The following is a description of a gene set: studied in species Homo sapiens Human Gene Set: chr6p22, and this is the list of marker genes: RNF39, OR2B6, H2AC10P, CDKAL1, H2AC1, OR2H5P, H2AC3P, H2AC5P, BTN1A1P1, BTN3A2, KDM1B (lysine demethylase 1B), OR2E1P, RPL13P, LINC02543, ACOT13, ZSCAN31, GPX6, ARPC3P5, GMNN, RN7SKP240, ENSG00000285761, OR2W1-AS1, SNORD32B, HLA-F-AS1, TRIM26, OR2W6P, OR2B2, POM121L2, NOP56P1, ZNF184, KRT18P38, JARID2-AS1, HLA-L, H4C3, UBQLN1P1, SOX4, RPL10P2, H2BC7 (NCBI Gene Id 8343), CMAHP, TMPOP1, RNU6-190P, H2AC17, HMGN4, H2BC2P, RPL5P20, H2BC3, H1-12P, H4C7, IFITM4P, PAIP1P1, H1-1 (H1.1 linker histone, cluster member), E2F3, E2F3-IT1, OR2B3, H2BC1, H2BC6, H2AC14, KIAA0319, H2AC16, IMPDH1P9, BOLA2P3, H4C8, RSL24D1P1 (ribosomal L24 domain containing 1 pseudogene 1), ENSG00000284607, H3C8, IQCB2P, HCG4, KIF13A, SUMO2P13, HCG11, OR2H1, SCGN, ENSG00000288887, ASS1P1, KRT18P1, SMIM15P2, HNRNPA3P17, HCG14, LNC-LBCS, H2BC12, MAS1L, ZSCAN26, RNU6-263P, HNRNPA1P1, BTN2A1, H2BC9, HCG9, NUP153, TRIM31-AS1, KRT8P43, ENSG00000287626, MCCD1P1, OR14J1, H1-2, NKAPL, RNA5SP205, LINC02829, H3C7, VN1R11P, SAR1AP1, HNRNPA1P58, H3C10, HLA-K, OR2N1P, OR2J1, GPLD1, HLA-F, SCAND3, OR12D3, KAAG1, RNU6-391P, OR2I1P, ZNF204P, C6orf62, HLA-J, DDX6P1, CANT1P1, PGBD1, MYLIP, RNU6-987P, CARMIL1, OR11A1, COX8CP1, RNU6-471P, DDX18P3, LINC01015, FAM8A1, OR2W1, MICC, OR12D2, ZDHHC20P1, UQCRFS1P3, RNU6-645P (RNA, U6 small nuclear 645, pseudogene), MCCD1P2, POLR1H, ENSG00000310015, H2AC15, DDX39BP2, MDH1P2, LOC124906556, OR5V1, LINC00581, RPS17P1, H2BC5, HLA-P, H4C6, LARRPM (NCBI Gene Id 100270746), H3C4, MICE, BTN3A1 (NCBI Gene Id 11119), ARMH2, RNA5SP204, LINC03003, ZSCAN23, HLA-W, RNU6-150P, H3C2, RPL23AP1, LARP1P1, TRIM27, ABT1, TRIM39-RPP21, MAS1LP1, H2BC6-AS1, HCG19P, H4C12, H1-3, ISG20L2P1, ENSG00000199851, OR2B8P, TMEM183AP1 (TMEM183A pseudogene 1), RNU6-502P, OR2W4P, H3C12, OR2W2P, H1-5, ENSG00000251830, SUCLA2P1, HLA-G, OR2U2P, OR2B7P, TRIM26BP, ENSG00000287359, HDGFL1, HLA-A, ENSG00000275846, PPIAP29, ZKSCAN4, UBD, RN7SL471P, ZNF90P2, OR1F12P, TOB2P1, H3P26, H2BC17 (H2B clustered histone 17), SLC17A3, OR2H4P, NBAT1, LINC00240, OR2J3, VN1R10P, LINC01556, RNU7-26P, H2AC6, H3C5P, STMND1, ATXN1-AS1, GPX5, RNU6-522P, CD83P1, H2AC2P, RNU2-62P, RANP1, OR2P1P, BTN2A2, H2BC16P, UBDP1, LINC02828 (NCBI Gene Id 105374978), CDCA7P1, VN1R12P, H2BC11, OR2B4P, RN7SL334P, POLR1HASP, MRPL42P2, MTCO2P33, POM121L6P, H2BC13, ZNF311, TRIM10, ZBED9-AS1, PRSS16, RPL29P17, CAP2, OR2J2, RNF144B, H2BP5, SUMO2P1, TRIM40, ZSCAN12P1, DCDC2, H2BC14, ZNF603P, MICD, H2AC12, MIR548A1HG, ENSG00000299570, TRIM15, MIR4639, ENSG00000305104, RPL6P18, HCP5B, H2AC11, H4C9, MRS2, RPL21P68, ZSCAN12, ZKSCAN8P2, H4C11, HCG18, RNU6-141P, RPL7P26, ZSCAN16, SLC17A4, H2AC9P, TRIM39, COX11P1 (NCBI Gene Id 140468), ZNF322, RNU6-930P, HCG4B, VN1R13P (NCBI Gene Id 387322), TPMT, H3C11, MOG, HLA-T, TRIM31, OR2U1P, OR2H2, HLA-V, KATNBL1P5, H4C2, ZSCAN9, ENSG00000233358, ZFP57, RPP21, H2AC4, HLA-N, ENSG00000288708, NHLRC1, MIR3143, H3C1, LINC03005, LINC01012, RIPOR2, HLA-E, BTN3A3, H2AC13, ESDP1, PRELID1P2, RPL8P1, ZNF165, H2BC10, MIR548A1, H2BC4, SLC17A2, H3C3, H4C4, TRIM38, OR2G1P, HCG9P5, GPR53P (NCBI Gene Id 9292), GPR89P, H1-4, RNU6-1114P, ENSG00000287050, H2AC8, H3C6, HCG15, SLC17A1, ZKSCAN8, DDX39BP1, RNU6-1060P, ZSCAN16-AS1, RPLP2P1, H2BC8, ZNF602P (NCBI Gene Id 493820), MICG, OR2J4P, LINC02980, CASC15, PRL, RPL21P61 (ribosomal protein L21 pseudogene 61), RPL36AP25, PPP1R11, RBM24, OR12D1, H2AC7, MCFD2P1, H3C9P, JARID2-DT, HCG4P8, RPL7AP7, ETF1P1, JARID2, LINC00533, LINC01623, MBOAT1, ATXN1, NUP153-AS1, GMPR, NGRNP4, RNU6-801P, RNU2-45P, OR2AD1P, H2BC15, AP3S1P1, HLA-H, RN7SL128P, H4C1, H1-6, HLA-U, BTN1A1, ALDH5A1, SPTLC1P2, GABBR1, HFE, UBE2D3P5, GUSBP2, RPL13AP, H4C5 (H4 clustered histone 5), NRSN1, BTN2A3P, ZKSCAN3, ZKSCAN8P1, TDP2, RPSAP2, DTNBP1, PERPP3, OR10C1, H4C13, NUP50P2, ZNF391, ID4, H4C10P, DEK